The following is a description of a gene set: Mouse Gene Set: GOBP_INTESTINAL_STEM_CELL_HOMEOSTASIS studied in species Mus musculus Any biological process involved in the maintenance of the steady-state number of intestinal stem cells within a population of cells., and this is the list of marker genes: Lpcat3, Znhit1, Pla2g2a, Pla2g10 (phospholipase A2, group X), Nod2, Lgr4